Given this list of marker genes FCER1G, HDAC2, AIM2, MAT2A, TFDP2, RTN4, MYOC, PARD6B, RAP1GAP2, UBE2L3, HIVEP1, PGC, IFIH1, TWIST1, SRP9, VAC14, AVL9, TCF4, PPARD, ID2, DGCR5, MUC6, PYGM, PRKRA, STAT1, PDHX, DLC1, STAU1, TSC22D2 (NCBI Gene Id 9819), GPX7, PPP1R3A, IDS, PUM3 (NCBI Gene Id 9933), UBE2V2, TNR, CYP2C9, SPINK4, PNP, SAP30, IL16, ATP2A2, GRIK5, NORAD, PFDN4, PBX2, CREB1, ZFYVE26, SNRPF, DMTF1, MLLT10, MAPKBP1 (mitogen-activated protein kinase binding protein 1), MCM2, DR1, NXF1, COPS8, CCL19, RFPL3S (RFPL3 antisense), NTS, CCR7, TGIF1, SLC31A2, MBTPS1, ADCYAP1R1, RUNX1, PEPD, NDUFC1, PTPN2, DNAJB4, QDPR, GATC, DUS4L, ELAVL2, OCLN, EDNRB, SCAF8, LETMD1, FRYL, REM1, MTHFS, GSK3A, SEC22B, IFRD1, CD53, PDCL, NR5A2, TNFAIP1, RELA, LINC01138, SLC25A16, SUSD5, FERMT2, CD96, PDGFA, IQSEC2 (NCBI Gene Id 4382), RAB2A, GADD45B, PKN2, CSNK1G2, RPA3, IL1RN, HNRNPH1, N4BP3, SOCS5, TFE3, IBTK, CTAG2 (cancer/testis antigen 2), OPTN, NECTIN2 (NCBI Gene Id 5819), PRKACB, RSAD2, LYZL6, KCNF1 (NCBI Gene Id 9036), SEMA4F (ssemaphorin 4F), RARA, HPS5, ANPEP, CERS6 (ceramide synthase 6), OSMR, C2orf72 (chromosome 2 open reading frame 72), MCC (MCC regulator of WNT signaling pathway), CHP2, UBE2J1, ABCB11, ANP32E, TRIP10 (NCBI Gene Id 9322), CFB, DTNB, ATP13A3, PRRG1, ACSL1, ELF4, ACADSB, CPA1, IRAK3, GRPEL1, CES1, PTPRCAP, RAP1GDS1, TRIB1, OPRM1, UCP3, CDKN2C, GRB7, MEF2D, RRAS2, BECN1, GBP2, PRPH, GNRH2, PRPSAP1, SKP2 (S-phase kinase associated protein 2), DLEC1, DSC3, IL10RB, USP19, UBE2D1, REPS1, SLC30A4 (NCBI Gene Id 7782), PROZ, ARSF, KCNK1, PLK1 (NCBI Gene Id 5347), SPRED2, OVOL3, IFT25, CELA2A, BAG2, TRIM38, BICDL1 (NCBI Gene Id 92558), IRF9 (NCBI Gene Id 10379), TAF2, HSPA6, MTF1, KYNU, DVL3 (dishevelled segment polarity protein 3), ZNF189, PPWD1, STAG2, VDAC2, INPP5B, BNIP3L, H2BC13, SERPINE1, ATRX, RHEB, GRIP1, PHC2, BCL2A1, F2RL3 (NCBI Gene Id 9002), ID1, AMHR2, IDO1, MKLN1 (muskelin 1), ARR3, MX2, TRIM27, MIR483, SSB, here is a description of the gene set: from publication Chaussabel D, Semnani RT, McDowell MA, Sacks D, Sher A, Nutman TB (PMID 12663451) Monocyte-derived dendritic cells (DC) and macrophages (MΦ) generated in vitro from the same individual blood donors were exposed to five different pathogens, and gene expression profiles were assessed by microarray analysis. Responses to Mycobacterium tuberculosis and to phylogenetically distinct protozoan (Leishmania major, L. donovani, Toxoplasma gondii) and helminth (Brugia malayi) parasites were examined, each of which produces chronic infections in humans yet vary considerably in the nature of the immune responses they trigger. species: Homo sapiens Genes down-regulated in comparison of macrophages versus macrophages exposed to M. tuberculosis. Human Gene Set: GSE360_CTRL_VS_M_TUBERCULOSIS_MAC_DN